Given this list of marker genes Tmco1, Appl2, Tmem94, Apoa1, Tbc1d1, Abhd5, Drd3, Soat2, Abl1, Fshr, Twnk, Slc9a6, Tunar, Angptl8, Has2, Slc8a3, Slc26a4, Gper1, Slc12a7, Kl (NCBI Gene Id 16591), Nr1d1, Atp2b2, Psen2, Mcu, Slco1a6, Park7, Lhcgr, Enpp1, Sod1, Ces1h, Aqp6, Gp9, Plscr3, Atp2c2, Ankrd26, Ppt1, Nnt, Smarca4, Ndufaf2, Snapin, Asgr2, Ireb2, Cnnm1, Gjb6, Abhd8, Vapb, Ank (NCBI Gene Id 52488), Ptch1, Mt3, Casr, Ndfip1, Lrp1, Ptpn2, Cngb1, Gpr21, Car2, Pih1d1, Fbn1, Stat3, Tmprss3, Cdh23 (cadherin related 23 (otocadherin)), Trpv4, Ryr2, Blvra, Mylip, Tesc, Gpr39, Ddx3x, Tasl, Ces1e, Gcm2, Cdk16, Pln, Lrrc8a, Oprk1, Mtch2, Dgat2, Ccl19-ps6, Plch1, Ywhae, Hmgn3, Diaph1, Fbn2, Ptk2 (NCBI Gene Id 14083), Glp1r, Atp2a2, Adra2a, Tmem178, Trim24, Calb1, Fcor, Ccr5, Slc1a3, Ern1, Adnp, Wnt5a, Abcb11, Slc30a10, Mir122, Tnfsf11, Edn3, Lamtor1, Jph2, Vdr, Slc34a1, Fabp5, F2, P2rx7, Trp53, Sar1b, Socs6, Tmprss6, Angptl3, Mcur1, Mbd5, Slc30a2, Bmp6, Clic4, Itpr1, Slc9a7, Tjp1 (NCBI Gene Id 381892), Atg7, Car4, Mup3, Unc13b, Sec24a, Cav3, Slc25a27, Npsr1, Pnpla1, Slc39a5, P2ry6, Tpp2, Ffar3, Atp4b, Ccl19 (NCBI Gene Id 24047), Fundc2, Micu3, Lamp1, Stxbp5l, Lipc, Chp2, Aqp3, Tm9sf4, Oas1f, B2m, Npc1, Nptn, Frey1, Osbpl2, Vps33a, Jagn1, Slc9a1, Pnliprp1, Pik3r2, Raf1, Atp6v1a, Slc4a1, Tsc22d4, Serpinf1, Kctd7, Oas1e, Or10j5, Lacc1, Abcg8, Adgrf5, Becn2, Slc39a8, Sco1, Rgn, Il6, Cav1, Rab7, Lcat, Ranbp2, Slc17a8, Ccl8, Wdr72, Tmem63b, Spns1, Fbxl5, Epas1, Hectd4, Car12, C2cd2l, Steap2, Rogdi, Tm6sf2 (transmembrane 6 superfamily member 2), Cnnm4, Acacb, Mir33, Eif2ak1, Slc24a5, Pax6, Hoxa3, Ryr1, Sin3a, Slc24a2, Gas6, Stk39, Cx3cl1, Sybu, Cln5, Ccl21d (C-C motif chemokine ligand 21D), Tlcd3a, Clcnkb, Phkb, Gramd1b, Capn3, Tcf7l2, Ncoa5, Slc34a3, Csmd1, Hmga1, Mcub, Enpp3, Dhps, Prnp, Dmtn, Kcnma1, Slc2a4, D1Pas1, Myh7b, Atp2c1, Rtn4, Selenok, Calca, Mir27a, Ptpn6, Cpb2, Birc5, Slc40a1, Pou3f3 (NCBI Gene Id 18993), Slc37a4, Itgb6, Tspoap1, Atp6v1b1, Grk2, Cftr, Cry2, Pde8b, Adipor2, Edn1, Heph, Lrp5, Snca, Hcfc1, Myh9, Lpcat1, Slco2b1, Nt5e, Gpr68, Lep, Abca5, Nr1h4, Lime1, Atp7b (NCBI Gene Id 11979), Itgb3, Abcd1, Bad, F2rl3, Cln6, Sgcd, Abca12, Cd24a (CD24a antigen), Bhlha15, Stim2, Klf7, Vegfa, Cib2 (calcium and integrin binding family member 2), Abca2, Cdkn2a, Abca3, Slc24a4, Glrx3, Stim1, Cckbr, Plcb3, Marcksl1, Ctrc, Sgk1, Atp1b2, Mir532, Corin, Sirt1, Bglap2, Slamf8, Picalm, Tent4b, G6pc2, Cartpt, Ccl21e, Fxn, Ogt, Abcc1, Lyn, Ncor1, Prnd, Anxa7, Mt2, Pdzd8, Ins2, Oca2, Minar2, Atox1, Zng1, Efhc1, Agt, Steap4, Fgfr1, Atp6v1g1, Erfe, Ptprv, Trpv5, Angptl4, Abca1, Col1a1, Tsku, Sv2a, Hmox1, Abcb7, Grn, Cry1, Adora1, Pygm, Epha5, Rraga, Coro1a, Letm1, Aplnr, Slc9a2, Chd7, Cisd1, Kcnh1, Sct, Plcl1, Mttp (microsomal triglyceride transfer protein), Meltf, Pnpla5, Gcg, Slc9b1, Sirt6, Chga, Gclc, Tlcd4, Slc39a7, Hpn, Tmem203, Rmdn3, Cacna1f, Atp1b3 (NCBI Gene Id 11933), Clstn1, Cemip, Scd1, Irs2, Mup4, Foxo1, Myc, Ager, Abcc6, Slc4a10, Ext2, Gls, Apoc4, Ephx2, Slc9a8, Dhrs7c, Fgfr4, Pdk2, Slc26a3, Rbp4, Sco2, Cox19, Mfn2, Il1a, Cmklr2, Kel, Scara5, Casq1 (calsequestrin 1), Stc1, Atp2b3, Commd9, Ormdl1, Pml, Spp1, Gck, Trem2, Ghrl, Ctsh, Sftpd, Ank1, Slc39a6 (NCBI Gene Id 106957), Trpm5, Ryr3, Cherp, Tmbim6, Oas1h, Mtss1, Ces1g, Ang2 (angiogenin, ribonuclease A family, member 2), Pla2g12b, Atp7a, Trpc1, Fgf2, Oxct1, Aco1, Gpi1, Lepr, Pde3b, Ptprc, Tmtc4, Ccn4, Lrrk2, Mir379, Hpx, Slc4a2, Trpc7, Atp13a2, G6pc1, Bmyc, Avp, Abcg4, Kcnj10, Dbi, Tmem199, Cacna1e, Surf4, Mon1a, Hamp, Atp6v0a4, Ednrb, Ttc39b, Cebpa, Mup11, Micu2, Hk3, Slc9a9, Bpifa5, Ccl21f, Slc39a13, Pde4d, Gpam, Prkaa2, Cd40, Idua, Slc4a11, Nadk, Fate1, Tlcd2, Cul5, Gdf2, Klf15, Ptprn2, Atp2a1, Gclm, Dbndd2, Wnk2, Pik3r1, Trf (NCBI Gene Id 22041), Rac1, Ormdl3, Hexb, Erbb4, Flna, Otc, Slc9b2, Ace (angiotensin I converting enzyme), Slc12a9, Nptx1, Xbp1, Pparg (NCBI Gene Id 19016), Pck2, P2ry2, Ccl19-ps1 (C-C motif chemokine ligand 19, pseudogene 1), Ces1a, Lipa, Tmem64, Lpl, Cltrn, Met, Ubash3b, Rnls, Gcgr, Mlxipl, Iscu, Ccdc47, Ftl1, Scnn1b, Tfrc, Ccl5, Avpr1a, Soat1, Tlcd1, Cyp39a1, Grina, Rab11b, Fkbp1a, Rps6, Tmem38a, Kcnj11, Klhl3, Atp6v0a1, Tiam1, Trpc2 (NCBI Gene Id 76847), Slc30a9, Ttpa, Slc39a4 (solute carrier family 39 (zinc transporter), member 4), Npy, Tgfb1, Wnt7b, Htt, Mecr, Smad2, Slc4a3, Tmem106b, Adck1, Or4m1, Gpr27, Insr, Mir320, Drd4, Gpld1, Pdk4 (NCBI Gene Id 27273), Grid2ip, Ccdc115, Pkd2, Prkaa1 (NCBI Gene Id 105952), Slc4a5, Tgm2, Ttc39d, Scn7a, Minpp1, Stxbp4, Atp6ap1l, Clcc1, Apoa4, Mia2, Nr1d2, Tcirg1, Kat5, Rhag, Ncs1, Anxa6, Cib3, Ldlr, Atp1a2, Rimbp2, Apoc2l, Pla2g4a, Cacna1a, Pomc, Pygl, Cyb5r4, Mcoln1, Usf1, Rora, Prkn, Stk11, Erc2, Stx4a, Alox5, Trdn, Asph, Ank3, Ptpmt1, Tmem63a, Slc12a4, Grin2b (glutamate receptor, ionotropic, NMDA2B (epsilon 2)), Cacna1s, Sri, Camk2d, Osbpl8, Nr3c2, Tmem165, Washc5, Cdh5, Frrs1, Aqp4, Rhd, Atp4a, Ppp1r3g, Gprc6a, Pla2g10, Foxk2, Prcp, Hnf4a, Slc35g1 (solute carrier family 35, member G1), Abhd4, Lcn6, Ldah, Slc29a1, Slc39a10, Rcn3, Calm1, Bcl2, Wnk3, Slc8a1, Hk2, Etnppl, Kcna5, Ccr1l1, Vsnl1, Atp6v0d2 (ATPase, H+ transporting, lysosomal V0 subunit D2), Ccl19-ps5, Thy1 (NCBI Gene Id 21838), Insig1, Nherf1, Zbed6, Abcb6, Rmi1, Th, Grik2, Plce1, Sfrp4, Sppl2c, Agtr1a, Prkce, Ces1f (NCBI Gene Id 234564), Nr1h2, Pcsk9, Neurod1, Calm3, Comt, Pold1, Kcna1, Ckb (creatine kinase, brain), Scarb1, Slc6a12, Xk, Rhcg, Ngf, Fcrl5, Inpp5k, Cyp11b2, Cnnm2, Fabp4, Slc9a4, Selenot, Ggcx, Rhbg, Plcg1, Foxk1, Trpc5, Ehd1, Zbtb20 (zinc finger and BTB domain containing 20), Bola2, Pik3ca, Slc25a46, Rab11fip2, Abcg1, Psen1, Rph3al, Kcnb1, Rab39, Arrb1, Hephl1, Btbd9, Micu1, Hamp2, Sesn2, Ibtk, Lncbate1, Hcrtr2, Htr2c, Scnn1a (NCBI Gene Id 20276), Tmtc2, Abcc8, Lamp3, Fgfr3, Mexis, Gp1ba (glycoprotein 1b, alpha polypeptide), Sidt2, Atp13a1, Gprc5b, Unc80, Car7, Spx, Stxbp3, Raly, Atp1b1, Ncoa6, Grin1, Pth1r, Slc11a2, Synpo, Slc30a1, Lgsn, Bak1, Fgf23, Fgf7, Slc9c1, Xcl1, Znhit1, Cav2 (NCBI Gene Id 12390), Nucb2, Hcrtr1, Ampd2, Foxa1, Foxa3, Piwil4, Slc4a9, Nkiras2, Ptk2b, Cyb561d2, Cln3, Foxo3, Cps1, Wnk1, Alas2, Ednra, Clec4b1, Hrc (histidine rich calcium binding protein), Atp13a5, Fxyd2, Abcg5, Obp2a, Cacna1c, Cyb561a3, Rab11fip5, Dynll1, Disc1, Plcb1, Slc4a4, Tmem174, Ces1b, Mir124a-1hg, Ptpn11, F2r, Adcy5, Atp6ap1, Bglap, Fmr1, Hk1, Bpifa1, Epb42, Ptprj, Bok, Rbm4, Sesn3, Nfat5, Dmxl2, Trpm2, Lck, Slc39a14, C7, Tgfb2 (transforming growth factor, beta 2), Itgav, Ccl19-ps3, Slc8b1 (solute carrier family 8 (sodium/lithium/calcium exchanger), member B1), Tmc8, Lima1, Kcnq1, Oas1b, Ncor2, Alpl, Mir369, Cst5, Mir192, Dmd, Ccr1, Fam20a, Xcr1, P2rx2, Egln1 (egl-9 family hypoxia-inducible factor 1), Il13, Malrd1, Atp12a, Nox4, Inpp4b, Adra1b, Slc24a3, Atp1a1, Naglu, Fundc2b, Trpc6, Smdt1, Plch2, Prkd1, Ftmt, Ntsr1, Napsa, Bax (BCL2-associated X protein), Calb2, Pth, Cnga1, Sv2b, Dgat1, Slc45a2, Gckr, Ces1c, Slc11a1, Rack1, Ucp2, Mt4, Car14, Fam3a, Atp2b4, Wnk4, Crh (NCBI Gene Id 383938), Rbp1, Nr1h3, Creg1, Slc2a2, Igf1, Slc4a7, Slc16a1, Myo5a, Foxa2, Mtln, Akr1b1, Srebf2, Arf1, Cyp7a1, Cybrd1, P2rx1, Baiap3, Rap1gds1, Cxcl10, Tnni3, Acaca, Med13, Pim3, Adrb1, Umod, Pnpla2, Akt1, Ms4a2, Bdkrb1 (NCBI Gene Id 12061), Mc3r, Cxcl9, Jsrp1, Ccr2, Slc41a1, Abcc2, Slc9a5, Ces1d, Ncoa4, Mir200a (microRNA 200a), Aqp11, Ifng (NCBI Gene Id 15978), Negr1, Hfe, Jph3, Slc12a8, Pkhd1, 1600014C10Rik, Pthlh (parathyroid hormone-like peptide), Vcam1, Ldlrap1, Tmem97, Npy1r, Fxyd1, App, Tlcd3b, Adipor1, Htr2b, Ccl21b, Slc17a7, Mbl2, Pacs2, Mbl1, Got1, Igfbp5, Atp1a3 (ATPase, Na+/K+ transporting, alpha 3 polypeptide), Cxcl11, Atp5f1b, Sox4, Adcy6, Ext1, Tra2b, Myt1, Pla2g6, Icam1, Vps54, Slc12a6, Slc4a8, Trmt10a, Acox1, Sucnr1, Aqp7, Apoc2, Calm2 (calmodulin 2), Map2k1, Prkcb (protein kinase C, beta), Htr2a, Mup5, Slc25a23, Bnip3, Cyba, Atp2b1, Hkdc1, Ctns, Ffar1, Aacs, Herpud1, Csrp3, Gip, Ero1b, Ptprn, Slc10a7, Osbp, Slc9a3, Dbh, Cox11, C1qtnf3, Plcg2, Spop, Pde4c, Sod2, Gpr89, Hps1, Star, Grm2, Slc66a1, Efna5, Lamp2, Oas1a, Atp6ap2, Ccl2, Slc1a1, Sstr5, Trpm7, Ero1a, Cacna1d, Dusp29, Apob, Pkp2, Nucks1, Sh2b2, Mir17, Lcn2, Ccdc22, Apoc3, Plcd1, Selenon, Gp1bb, Gsto1, Htr1b, Hap1, Eif3e, Srf, Glul, Nubp1, Smarcb1, Ngfr, Stc2, Vgf (NCBI Gene Id 381677), Ddit3, Ffar2, Kcne3, Pax2, Slc12a5, Rab38, Mir410, Sypl2, Ano1, Cnnm3, Cln8, Ppard, Slc24a1, Tfr2, Fthl17e, Cnr1, Letmd1, Plcb4, Xpr1, Wfs1, Mtnr1b, Fasl (NCBI Gene Id 14103), Ppp3cb (protein phosphatase 3, catalytic subunit, beta isoform), Atf4, Crtc2, Pnlip, Casq2, Lyst, Slc38a3, Atp6v0d1, Trpa1, Slc31a2, Mapk1, Cox10, Kdr, Endog, Tspo, Hsdl2 (hydroxysteroid dehydrogenase like 2), Pde1c, Sgcb, Smad5, Nkiras1, Nppc, Ormdl2, Sctr, Scnn1g, Cyp7b1, Slc8a2, Trpm8, Eny2, Hmox2, Hyal2, Npc1l1, S100b, Hmgcr, Ier3ip1, Cyb561, Lrrc8d, Lin28a, Nol3, Guca2b, Ube3a, Fto, Cacnb2, P2ry1, Pex2, Mir337, Kctd17, Dmxl1, Slc17a6, Cp, Usf2, Hif1a, Cacnb4, Alms1, Slc26a9, Trpc3, Prkca, Steap3, Aqp2, Bloc1s6, Atg5, Thada, Ccl19-ps4, Oas1g, Rnasek, Hnf1a, Fosl2, Trpc4, Pck1, Neo1, Gpr3, Gpr12, Mapk3, Ppp3ca, Atp13a4, Grm1 (glutamate receptor, metabotropic 1), Tmem38b, Tpcn2, Hvcn1, Npc2, Cert1, Slc26a6, Mup2, Hjv, Maip1, Wdtc1, Dmpk, Fkbp1b, Ins1, Agtr2, Plcl2, Mettl21c, Gpihbp1, Erc1, Bace2, Ccl21a, Mafg, Igf1r, Oas1c, Tmem175, Tbxas1, Gpx1, Oas1d, Nfe2l1, Trpm4, Immt, Cyp27b1, Slc30a8, Mt1, Atp1a4, Nus1, Asl, Ccl3, Aqp1, Slc30a5, Fzd9, Slc12a1, Aspscr1, Hdac9, Commd1, Ank2, Tmc6, Cdk5, Akap11, Smad1, Slc12a3, Mpc2, Adissp, Gp5, Itpr2 (NCBI Gene Id 545892), Gstm7, Il18, Fth1, Pnliprp2, Camk2n1, Ttc7, Atp2a3, Prkaca, Bsnd, Slc7a11, Slc12a2, Rptor, Atp13a3, Adcy8, Tmem9, Map4k4, Stoml2, Acvr2b, Rfx6, Slc34a2, Tex101, Edn2, Mllt6, Abcb4, Calcb, Ccdc186, Crhr2, Plcb2, Snx10, Drd1, Gk, Mustn1, Atp6v1b2, Atp6v0a2, Smad4, Enpp7, Pik3cb, Kcnh2, P2ry4, Afg3l2, Mup1, Hps6, Errfi1, Ciao3, Cd19, Aplp2, Rab34, Pnpla3, Lipg, Ap3b1, Mir130a, Ghitm, Brsk2, Slc39a12, Nr5a2, Fitm2, Upk3a, Rab20, C1qtnf12, Smad3, Kif5b, Pfkm, Cxcr3, Chp1, Trpv6 (NCBI Gene Id 64177), Adipoq, Kcnj16, Akap6, Pnpla8, Fech (NCBI Gene Id 14151), Drd2, Fabp3, Apoa5, Apoe, Pdx1, Atp6v0c, Apoa2, Slc30a7, Pdpk1, Ankrd9, Slc39a9, Itpr3, Slc31a1, here is a description of the gene set: studied in species Mus musculus Any biological process involved in the maintenance of an internal steady state of a chemical. Mouse Gene Set: GOBP_CHEMICAL_HOMEOSTASIS